The following is a description of a gene set: species: Homo sapiens Human Gene Set: GOBP_REGULATION_OF_ATP_BIOSYNTHETIC_PROCESS Any process that modulates the frequency, rate or extent of ATP biosynthetic process., and this is the list of marker genes: TAFAZZIN, PID1, VCP, PRKN, ADCY10, NDUFC2, STAT3, IL4, ATPSCKMT, PINK1, ANTKMT, MIR675, ATP5IF1, TMSB4X, ENO1, TREM2, PARP1, MAP2K1, DNAJC30, SPHK2, PPARA